The following is a description of a gene set: We hypothesized that DNA methylation distributes into specific patterns in cancer cells, which reflect critical biological differences. We therefore examined the methylation profiles of 344 patients with acute myeloid leukemia (AML). Clustering of these patients by methylation data segregated patients into 16 groups. Five of these groups defined new AML subtypes that shared no other known feature. In addition, DNA methylation profiles segregated patients with CEBPA aberrations from other subtypes of leukemia, defined four epigenetically distinct forms of AML with NPM1 mutations, and showed that established AML1-ETO, CBFb-MYH11, and PML-RARA leukemia entities are associated with specific methylation profiles. We report a 15 gene methylation classifier predictive of overall survival in an independent patient cohort (p < 0.001, adjusted for known covariates). Human Gene Set: FIGUEROA_AML_METHYLATION_CLUSTER_5_UP species: Homo sapiens from publication Figueroa ME, Lugthart S, Li Y, Erpelinck-Verschueren C, Deng X, Christos PJ, Schifano E, Booth J, van Putten W, Skrabanek L, Campagne F, Mazumdar M, Greally JM, Valk PJ, Löwenberg B, Delwel R, Melnick A (PMID 20060365) Cluster 5 of aberrantly hypermethylated genes in blasts from AML (acute myeloid leukemia) patients., and this is the list of marker genes: TIGD3, CANT1, CRHBP, NRP2, GTF2A1, KRT81, PMAIP1, PABPN1, ADGRG6, ZNF667, HMCES, PIAS2